Given this list of marker genes SDC2 (NCBI Gene Id 6383), DNAJA2, DMRTC2, UCHL5, MED13, IL4R, SSX2B (NCBI Gene Id 727837), MAP3K1, FBXO28, FHL1, NFIA, PRAMEF25, MBTD1, SEMA3A, SPATA12, AMACR, KCNA2, MAML3, C8orf34, FAM222B, PRR20D, NRF1, RETREG1, CPNE4, PRAMEF4, CNKSR2, IGFBP1, MFSD6, CTCF, FOXN3, KCNH7, NHEJ1, TMX3, TSPAN33, SLITRK1, ZNF829, MDGA2, EBF1, TTYH2, ZBTB25 (NCBI Gene Id 7597), HES7, PHKA1, SRC (SRC proto-oncogene, non-receptor tyrosine kinase), TCEAL7, TCEAL5, TSPAN2, PRMT2, CCDC47, FBXL20, ARIH1, RIMS2, KCNAB1, YWHAE, SERTAD2, GUCY1A2, PLA2G4E, KLHDC2, TIGD3, MAPK6, HERC2, SPAM1, SLC9A7, PRR20B, JPH4, PRKCI, SEPHS1, CCNT2, PRR20E, ZNF440, GPC3, DNMT3A, CPEB2, PCED1A, APTX, NFIB, RAB3IP, C8orf58 (chromosome 8 open reading frame 58), CERT1, TRHDE, RASA1, EXTL2, PRR20A, ZC3H12B, FAM118A, ORC5 (NCBI Gene Id 5001), PAQR9, SSX2, TP53BP1, SSX3, KRT10, MAP3K13, USP49, GPR155 (NCBI Gene Id 151556), TCEAL3, TLCD4, PPP1R9A, RPL32 (NCBI Gene Id 6161), SLC8A1, PPP2CB, KCNK9, DIDO1, FGF13, COL25A1, BEX1, PURB, CSTF2T, DDHD2, CGGBP1, ZNF439, PNPLA8, TTPAL, ABCB10, ARL5B, ZFAND5, NR3C1, TMPRSS15, CNTNAP3B, ADRB2, PIAS2, SYNE2, TMOD2, CNTNAP5, ANK3, TACR1, TPSAB1, CHL1, ENTPD6, MCUR1, ARID2, PRAMEF15, BEX3, TMEM9, NFYC, EFCAB11, ZNF354A, BEX2, EGR1, MYBL1, RAB4A, BTG1, TRARG1, MAP2, TPSB2, PRR20C, SEMA3D, RNF146, CAMK2D, MB21D2, here is a description of the gene set: Genes predicted to be targets of miRBase v22 microRNA hsa-miR-5581-3p in miRDB v6.0 with MirTarget v4 prediction scores > 80 (high confidence targets). Human Gene Set: MIR5581_3P from publication Chen Y, Wang X (PMID 31504780) studied in species Homo sapiens